The following is a description of a gene set: Genes down-regulated in epithelial cells (6h): untreated versus interferon alpha. species: Homo sapiens from publication Sanda C, Weitzel P, Tsukahara T, Schaley J, Edenberg HJ, Stephens MA, McClintick JN, Blatt LM, Li L, Brodsky L, Taylor MW (PMID 16800785) Type I and type II interferons (IFNs) bind to different cell surface receptors but activate overlapping signal transduction pathways. We examined the effects of a type I IFN (IFN-acon1) and a type II iFN (IFN-g1b) on gene experession in A549 cells and demonstrate that there is a common set of genes modulated by both IFNs as well as a set of gene specifically regulated by each, reflecting the activation of different signaling pathways. In particualr, IFN-g induced many more genes of the signaling pathways, apoptosis, and cytokine interactions than did IFN-a. Even with genes induced by both IFNs there were distinctive quantitativive differences in expression. IFN-g1b plays a major role in the induction and regulation of the complement pathway. Previous work has shown a synergistic antivral and antiproliferative effect of type I and type II IFNs in cell culture and in the treament of tumors in mice. We demonstrate that a majority of genes showed and additive effect of IFN-acon1 and IFN-g1b, but a subset of gene is synergistically induced; these incluce ISG10, MX2, OAS2, and other genes known to be involved in the antiviral response, TRAIL (TNFSF10) and caspases involved in apoptosis and chemokine genes RANTES, CXCL10, and CXCL11. Greater than additive transcription of some of these genes in the presence of both IFNs was confirmed by real-time kinetic RT-PCR. Elevated induction of many of these genes may be sufficient to explain the synergistic antiviral and antitumor effects of this combination of IFNS in vivo. Human Gene Set: GSE5542_UNTREATED_VS_IFNA_TREATED_EPITHELIAL_CELLS_6H_DN, and this is the list of marker genes: AK2, NSL1 (NSL1 component of MIS12 kinetochore complex), CHMP7, PPM1N, LEF1, ZNF770, SHISAL2B, ALDH3A2, C1GALT1, TMEM229B, GLUD1, RASGRP2, ZNF569, CLNS1A, PLEKHG4, OSGEPL1, GAS2, PLAG1, GABBR1, IGF1R, ZNF711, ALDH5A1, ZNF91, ANGEL1, SGCB, HSPD1, TRABD2A, TMEM263, ZC3HC1, ELOVL4, JAK3, UBAC2, FAM86DP, ZNF263, LRRN1, SERTAD2, FNDC3B, ANKRD46, NCOA4, MSRA, KIAA0040, EFHC1, PTGR2, PNRC2, EPCIP-AS1, TMOD2, ATG10, ARHGAP32, PLXDC1, FAM229B, ZMYND8, SUCLG2, LGMN, SLC43A2, CFAP418, MMP28, KANSL1L (NCBI Gene Id 151050), SUMF1, PGAP2, ZNF84, SLC8B1, TTPAL, HOOK1 (hook microtubule tethering protein 1), SNX16, RAPGEF6, MCEE, CD8B, FUNDC2, PFAS, CACHD1, ZC3H12B, CBY1, LINC01356, MPZL1, ETFRF1, TOM1L2, USP53, THEMIS, GFOD3P (Gfo/Idh/MocA-like oxidoreductase domain containing 3, pseudogene), AK3 (adenylate kinase 3), RABL3, ANAPC16, IQCA1, BCORP1, ACTN1, INO80B, SLC7A8, SUCLA2, ARMCX1, ZNF239, TCF7L2, GAL3ST4 (galactose-3-O-sulfotransferase 4), PCYOX1L, CLUAP1, ZFYVE16, CHCHD7, ACKR3, TRUB1, DUS1L, PALS2, PIGM, TIMP2, APP, AASDH (aminoadipate-semialdehyde dehydrogenase), UCP2 (uncoupling protein 2), FBP1, PIM2 (NCBI Gene Id 11040), SPPL2B, ATG4C, TEX9, NRCAM, SCRN1, HLA-DOA, EEA1, FMO4, NOG (noggin), PDK1, PPFIBP1, TENT5A, CSGALNACT1, PGBD4, DDX60L, ATL1, ADGRE4P, GIN1, PXYLP1, GCA, SNORA5C, ZNF766, PBX3, ZP3, EIF3E, ARRB1, WDR73, ZFAND1, ZFP2, KRT2, CDH23, ZNF419 (NCBI Gene Id 79744), IFI6, RMDN2, SNTG2, ZNF485, BCKDHB, SNORA50A, MTA3, SSBP2, GIMAP1, SDK2, CEP41, CAMSAP2, NUCB2, NBEA, TRIM2, LCE1C, ZKSCAN7, PAFAH2, DHRS7, NDFIP1, PRDM5 (PR/SET domain 5), ARHGEF11, N4BP2L1, CREB1, TMEM38B, STK17B, GP5, CNN3, ARHGAP17, CYP2J2 (NCBI Gene Id 1573), SUCLG2P2, PLCL1, MANEA, SPATA6, RBM43, LTA4H, KCNQ1, PRKD3, EIF2D, SCAND2P, OR2AK2, RAD54B, AP2A2 (adaptor related protein complex 2 subunit alpha 2), KCNQ5, PJA1, PPFIBP2, PUS3 (NCBI Gene Id 83480), SPART, PTPRK, BCL9, ZNF12, IL17RA, CARMIL1, OSBPL5, SMARCA2, NMNAT3, PRPF38A, DENND5A, TOP1MT